Given this list of marker genes Gpx4, Hpgd, Alox5, Alox15, Lta4h, here is a description of the gene set: Biosynthesis of E-series 18(S)-resolvins studied in species Mus musculus Mouse Gene Set: REACTOME_BIOSYNTHESIS_OF_E_SERIES_18_S_RESOLVINS